The following is a description of a gene set: species: Mus musculus Genes predicted to be targets of miRBase v22 microRNA mmu_miR_130b_3p in miRDB v6.0 with MirTarget v4 prediction scores > 80 (high confidence targets). Mouse Gene Set: MIR_130B_3P from publication Chen Y, Wang X (PMID 31504780), and this is the list of marker genes: Atg16l1, Pmepa1, Lrrtm2, Enpp5, Lgalsl, Map3k8, Abcc5, Fut9, Emx2, Lonrf3, Zfp113 (zinc finger protein 113), Cdk19, Skida1, Fcho2, Nsd3, Pparg, Sphk2, Tnrc6c, Erbin, Blcap, Prkd3, Mid1ip1, Akap11, Rab5a, Stx6, Cmpk1 (NCBI Gene Id 66588), Slmap, Hoxb1, Reps2, Cyld, Btaf1, Rfx7, Dennd10, Gja1, Smad5, Spred1, Rnf38, Abhd3, Thsd7a, Sowahb, Cfl2, Atp2b2, Prr14l, Zbtb18, Lrp8 (low density lipoprotein receptor-related protein 8, apolipoprotein e receptor), Arhgap1, Socs6, Mb21d2, Maf, Gon4l, Nectin3, Acer2, Arhgap21, Zbtb4, Ptp4a1, Tnf, Tbc1d8, Ppp6r1 (protein phosphatase 6, regulatory subunit 1), Ston2, Elk3, Cd69, Kmt2c, Il25, Tsc1, Nacc2, Klhl20, Cbfb, Pgm2l1, Smarcd2, St18, Pxk, Mdm4, Miga2, Tapt1, Zcchc14, Fmr1, Relch, Usp32, R3hdm1, Gpatch8, Pik3cb, Kcna4, Mapk8, Casd1, Larp4, Mmgt1, Cnot6, Esr1, Sh3d19, Ptprg, Ldlrad4, Tshz1, Tspyl2 (NCBI Gene Id 77013), Mat2b, Snapin, Jmy, Pou4f1, Snx5 (NCBI Gene Id 99195), Stim2 (stromal interaction molecule 2), Tet3, Sybu, Rtn1, Tmem250, St6galnac3 (NCBI Gene Id 20447), Zmat3, Dpysl2, St8sia5, Pdgfra, Med12l, Pak6, Psd, Phaf1, Cast, Ldaf1, Stxbp5, Jarid2, Dnajc24, Btg1, Plcb1 (NCBI Gene Id 98861), Socs5, Prkaa1, Snx2, Spire1, Cyyr1, Btbd3, Mctp1, Dennd1a, Chst1, Mphosph9, Gpr137c, Heg1, Psd3, Smoc2, Ccny, Bnip2 (BCL2/adenovirus E1B interacting protein 2), Stimate, Mdn1, Clip1, Ago1, Mon2, Akirin2, Laptm4a, Sulf1, Tbl1xr1, Tbcel, Cpeb1, Rnf216, Wnk1, Calm2, Psap, Jade1, Mex3d, Phf3, Mybl1 (NCBI Gene Id 17864), Memo1, Csmd1, Csnk1g1, Tes, Lrig1, Cnot7 (NCBI Gene Id 18983), Lrp4, Lonrf1, Iqgap2, Fastk, Map3k12, Wdfy3, Fam234a, Itpr1, Brwd1, Mapk1, Phf12, Kbtbd8 (kelch repeat and BTB (POZ) domain containing 8), Spart, Snip1, Mllt6, Arhgap12, Tbc1d12, Ubl3, Med15, Vps37a, Garem1, Atxn1, Ddx6, Tgfbr1, Ube2d2a, Clcn3, Npepl1, Nckap5, E2f2, Rasd1, Fermt2, Ccdc126, Usp8, Mbnl1, Zfp11, Gga3, Sel1l3, Ulk2, Appl1, Vps29, Acbd5, Smap1, Hprt1, Btf3l4, Eogt, Dll1, Pcnx1, Rap2c, Mfsd6, Neurog1, Plekhg5, Rbbp8, Btbd7, Wee1, Daam1, Acsl1 (NCBI Gene Id 56355), Ar, Dsel, Wnt2b (NCBI Gene Id 22414), Epc2, Fibin, Acsl4, Togaram1, Caprin2, Sbno1, Sgcb, Nol4, Ago4, Impdh1, Naa30, Adamts20, Ankib1, Dcbld2, Gng12, Cep170, Ereg, Acvr1, G3bp2, Dgke, Hs3st5, Clcn5, Robo2, Mecp2, Adcy1, Mdfic, Cds1, Zfp609, Cltc, Eda, Lcorl, Kcnj2, Zfp655, Bahd1, Smoc1, Arap2, Kdm2a